Given this list of marker genes FBRSL1, DRC3 (NCBI Gene Id 83450), OAS1, RPRD1A, XPO4, KCNA4, MACROD2, CAPRIN1, SARNP, MAPRE2, RWDD2A, PFN2, TMPRSS13, TM4SF18 (NCBI Gene Id 116441), DENND1B, STON2, BACE1, CCZ1, PDS5B, CCZ1B, PAK1, NSD3, STK40, TMPPE, TOR1B, KPNA3, RAP1B, ZNF611, COG3, FPR3, MAGI3, DDX3X, CCDC40, PDZD7, CLASP2, CRTAM, CNKSR2, MIA3, PDCD2, ATAD2B, TRIM58, here is a description of the gene set: Genes predicted to be targets of miRBase v22 microRNA hsa-miR-6808-3p in miRDB v6.0 with MirTarget v4 prediction scores > 80 (high confidence targets). from publication Chen Y, Wang X (PMID 31504780) Human Gene Set: MIR6808_3P studied in species Homo sapiens